The following is a description of a gene set: Pyruvate metabolism studied in species Homo sapiens Human Gene Set: REACTOME_PYRUVATE_METABOLISM, and this is the list of marker genes: PC, RPS27A, PKLR, PDK1, UBA52, PDHB, PKM, VDAC1, RANBP9, DLAT, PDHA1, MPC2, PDHX, NEK1, DLD, GPT, MAEA, GLO1, WDR26, FAHD1, ARMC8, ME3, MPC1, RMND5B (required for meiotic nuclear division 5 homolog B), LDHC, PDP1, RMND5A, LDHAL6B, UBB, GID4, ME1, GSTZ1, ME2, MKLN1, PDK3, PDK4, PDPR, LDHA, UBC, PDK2, GID8, SIRT4, MPC1L, LDHAL6A, PGAM5, PDP2, HAGH, LDHB, PDHA2